Given this list of marker genes SELENON, PACS2, PDZD8, PSEN2, ATP2A2, CALM1, AHCYL1, VMP1, here is a description of the gene set: Human Gene Set: GOBP_MITOCHONDRION_ENDOPLASMIC_RETICULUM_MEMBRANE_TETHERING The attachment of a mitochondrion and an endoplasmic reticulum via molecular tethers that physically bridge their respective membranes and attach them to each other. The tethering may facilitate exchange of metabolites between the organelles. studied in species Homo sapiens